The following is a description of a gene set: studied in species Homo sapiens Aplastic clavicle Absence of the clavicles as a developmental defect. Human Gene Set: HP_APLASTIC_CLAVICLE, and this is the list of marker genes: ORC1, SALL4, PTDSS1, CDC6, RUNX2, CDT1, RNU4ATAC, CTSK, PTH1R, ATP7A, PIGL, ORC4, RNU12, ORC6, GMNN, CBFB, FIG4, KIAA0586, CDC45